The following is a description of a gene set: Mouse Gene Set: REACTOME_FGFR2_LIGAND_BINDING_AND_ACTIVATION studied in species Mus musculus FGFR2 ligand binding and activation, and this is the list of marker genes: Fgf9, Fgf20, Fgf5, Fgf4, Fgfbp1, Fgf3, Fgf10, Fgf6, Fgf1, Fgf22, Fgf23, Fgf17, Fgfbp3, Fgf18, Fgf8, Fgf2, Fgf7, Fgf16 (NCBI Gene Id 80903)